Given this list of marker genes Prdx3, Ppdpf, Trappc4 (NCBI Gene Id 80545), Hnrnpr, Eif1ax, Sft2d1, Hs3st1, C4b, Oard1, Tex261, Sdf4, Aldoc, Acyp2, Gabarapl2, Rexo1, Rps14, Rplp1, Ddc, Qdpr, Adprh, Eif5, Cfdp1, Mrpl4, Arl6ip4, Hmox2, Rab3a, Epdr1, Prkrip1, Nedd8, Paqr6, Nudt9, Fdps, Fkbp3, Rnf5, Akap9, Ube2v1, Mif4gd, Copz1, Glrx3, Mpv17l2, Arl4d, Fkbp8, Polr1d, Nme2, Arl8a, Ak2, Gstm1, Ndufab1 (NADH:ubiquinone oxidoreductase subunit AB1), Ik, Dbi, Rpp30, Tm2d3 (NCBI Gene Id 77179, TM2 domain containing 3), Rbm8a, Cdkn2d, Mbp, Pdap1, Tmem11, Frg1, Rpl19, Plin3, Poc1a, Gpt, Erh, Babam1, Denr, Ptpn11, Hpf1, Marf1, Brd3, Dnajb2, Fam89b, Psme2, Creg1, Pgp, Ndufs2, Trp53bp2, Unc50, Gid4, Atp6v1d, Polr2i, Aptx, Ift27, Polr2a, Pithd1, Banf1, Psma5, Ptms, Ddah2, Pole4, Ddrgk1, Otud7b, Cenpx, Dlgap4, Ube2d1, Stmn1, Ip6k2, Wbp2, Cyc1, D8Ertd738e, Emc7, Ninj2, Nfix, Aup1, Sdhd, Snw1, Scg5, Serpinf1, Frat1, Pmm1, Ube2m, Arpc5l, Cox4i1, Zfp414, Gtf2b, Tnni1, Mrpl14, Mrps25, Tmt1a, Emc6, Mea1, Cd63, Eif3f, Rpl11, Mpdu1, Vps72, Sra1 (NCBI Gene Id 24068), Rps8 (ribosomal protein S8), Bckdha, Iftap, H2bc27, Shisa5, Cox8a, Map1lc3b, Emc8, Selenbp1, Polr2e, Atp5mc3, Scp2, Cops6, Vps28, Micos13, Ruvbl1, Naca, Rex1bd, Ypel3, Vgll4, Ndufs3, Psmb1, Ifi27, Phb2, Trappc6b, Ncoa3, Nudc (nudC nuclear distribution protein), Arl2, Prdx5, Rpl4, Otub1, Sec11c, Sh3bgrl3, Atp5pd, Calm3, Psmb6, Raly, Mrpl28, Psmb3, Ccdc85b, S100a1, Acot13, Aig1, Ech1, Cfl1, Mmp24os1, Tmem9, Txn2, Commd6, Pfdn1, Chmp5, Atp5mc2, Mvb12a, Litaf, Pde6d, Myg1, Rps19, Gabarap, Arf1, Enho, Rsu1, Snca, Aprt, Scand1, Ebpl, Vdac3, Znhit1, Ubxn1, Tbcb, Sfr1, Ccs, Brms1, Srsf9, Gatd3a, Dusp15, Fuca1, Apoe, Sf3b5, Hmgcl, Pdrg1, Spcs2, Ndufb11, 0610010K14Rik, Sbds, Psma2, Gstk1, H2-D1, Hspa1a, Sphk1, Npdc1 (neural proliferation, differentiation and control 1), Twf2, Imp3, Ubald1, Mrpl42, Ndufb5, Mrto4, Ppp4c, Manbal, Rab14, Tmem205, U2af1, Sparc, Vcf1, Tmem98, Eri3, 1110004F10Rik, Abca8a, Stard3nl, Zmat2, Commd5, Snrnp48, Grpel1, Cope, Gnao1, Ppp1r11, Tmed3, Dbndd2, Mrps17, Rack1, Nmral1, Tspo, Mxd4, Ssr2, Prelid1, Reno1, Tmed4, Vdac2 (voltage-dependent anion channel 2), Xpa, Spr, Sdhb, Srsf5, Dcps, Tmem106c, Dnlz, Map2k2, Dstyk, Tmsb4x, Commd9, Eif3k, Fcf1 (FCF1 rRNA processing protein), Acy1, Apod, Bfsp2 (NCBI Gene Id 12076), Ube2e2, Anxa2, Nkiras1, Taf9, Tuba1b, Hsp90ab1, Tmem50a, Rnasek, Rnf167 (NCBI Gene Id 74807), Gstm7, Scamp3, Ddt, Srd5a3, Dda1, Commd3, Medag, Rpsa, Mocs2, Pcbp2, Jtb, Atp5f1d, Adh5, Ndufa13, Rps11, Mrpl20, Ciao2b, Lamtor2, Cystm1, Pgls, Fbxo7, Klf7, Ctnnbip1, Rhoc, Ten1, Rabac1, Spag7, Impact, Eif1, Kdelr1, Pin1, Hsd17b10 (NCBI Gene Id 15108), Higd2a, Id3, Tmem147, Dtd1, Pdcd6, Dapk3, Sdf2l1, Ube2k, Tma7, Ccdc124, Tbcel, Commd10 (NCBI Gene Id 69456), Ociad1, Fth1, Selenok, BC031181 (cDNA sequence BC031181), Gadd45gip1, Lcmt1, Brd4, Lamtor5, Prdx1, Sdhc, B3gat3, S100b, Fus, Psmd4, Sf3b4, Fis1, Ubxn4, Rps20, Zmat5, Exosc7, Drap1 (NCBI Gene Id 66556), Bpgm, Smim14, Rab11b, Ptpmt1, Aldoa, Psmc5, Lrp4, Supt4a, Pdcd5, Jagn1, Tmed9, Hspe1, Akt1s1, Tmem14c, Czib, Cd9, Fbln1, Sin3b, Rplp0, Rpl28, Psmb5, 2310011J03Rik, Commd8, Klf13, Tmem109, Clpp, Ddx39b, Ino80e, Ctsz, Pdlim2, Eif1b, Ttc1, Mrps12, Gm2a (NCBI Gene Id 552880), Nabp2, Coa3, Polr2g, Dnajc3, Wdr83os, Ino80b, Anxa5, Zftraf1 (zinc finger TRAF type containing 1), Bag6, Tomm40, Hagh, Srm, Mycbp2, Mettl26, Abcg1, Esd (NCBI Gene Id 51790), Zfp317, Sar1b, Hras, Lsm10, Bnip3l, Iscu, Fn3k, Gstm5, Pagr1a, Ier2, Lefty1, Metrn, Ddost, Skap2, Dohh, Atp5f1c (ATP synthase F1 subunit gamma), Txndc12, Nosip, Ppia, Tcf7l2, Med28, Samm50, Pigp, Ppp1ca, Nudt16l1, Eif3m, Jund, Mtarc2 (NCBI Gene Id 67247), Elavl3, Vti1b, Tspan7, Srp9, Zcchc17, Gng11, Dnajc4, Cend1, Cavin3, Taf13, Mrpl48, Psmc4, Med8, Pex16, Imp4, Wipi1, Rab4b, Tppp3, Ebna1bp2, Mblac2, Snx15, Rpain, Lsm2, Cisd1, Mad2l2, Slc50a1, Mrpl30, Mpst, Rbm42, B2m, Timm22, Adrm1, Slc25a3, Gnb1, Cnih4, Rbfa, Atp5pf, Timm13, Car2, Rpl14, Mrpl15, Cttnbp2nl, Ap2a1, H2az1, Pqbp1, Med27, Ftl1, Ndufs4, Chd4, Tpt1, Pkm, Gemin7, Itgb5, Phlda3, Dctn3, Nfkbia (NCBI Gene Id 18035), Med19, Hnrnph3, Nme1, Tpgs1, Psmc3, Lmna, Mrps26, Arhgdia, Kif1a, Cycs, Eif4a3, Nol7, Mrps6, Zfp580, Smim30, S100a16, Gapdh, Mrpl18, Pou3f1, Gng10, Tpd52l2 (NCBI Gene Id 99179), Galk1, Elof1, Psma4, Rcor3, Tmod2, Uqcrc1 (NCBI Gene Id 66186), Sptssa, Hypk, Ndufv2, Zfp36, Arpc1a, Shisa4, Rpl18a, H2-K1, Glrx2 (glutaredoxin 2), Szrd1, Snrpd2, Pold2, Mrpl2, Taldo1 (transaldolase 1), Cacybp, Cetn3, H2bc4, Rbm25, Serbp1 (NCBI Gene Id 66870), Emc10, Cirbp, Micu3, Smim12, Ctsb, Cops5, Hmgn2, Syf2, Stmn4, Nt5c3b, Mtcl3, Eif3i, Ywhae, Psma3, Brcc3, Anapc16, Tmbim4, Rpl35, Myl6, Cdc37, Psip1, Dcdc2a, Junb, Mrpl41, Thap7, Trir, Lrrc4b, Stoml2, Arl6ip5, Rpl9 (NCBI Gene Id 20005), Nkx2-2, Tssc4, Tmem208, Gpatch11, Tm2d2, Erp29, Stmp1, Ndufa12, Idh3g, Rps5, Abcf1, Psmd13, Ndufs6, Parl, Tomm22, Srp14, Ngdn, Pnrc1, Hint1, Pigyl, Dmac1, Sys1, Mettl5, Anp32b, Cuta, Il11ra1, Mapre3, Cyb5r3, Paxx, Med4, Ptpn1 (NCBI Gene Id 19246), Atp6v0b, Ubb-ps, Pcbp4 (NCBI Gene Id 80436), Bax, Ciao2a, Zscan26, Ap2s1, Snrpb, Opalin, Oaz1, Clta (NCBI Gene Id 230110), Hcfc1r1, Hdgf (heparin binding growth factor), Fos, Smad7, Ptp4a2, Wdr18, Nr4a1, Auh, Atp5mc1, Tsn, Arpc1b, Hmgb1, Dnajc9 (NCBI Gene Id 68076), Ift22, Mmp2, Ctsl, Abhd17a, Eef1g, Dynlrb1, Nsmce1, Samd4, Grina, Swi5, Sertad1, Nucks1, Ssna1 (SS nuclear autoantigen 1), Atraid, Sarnp, Hmgn1, Eci1, Ldhb, Zfyve21, Pllp, Ube2e3, Ubl7, Rpl24, Snrnp70, Mdh2, Ndufb10, Atp5po, Snrpd3, Arpc4 (NCBI Gene Id 68089), Camk2n1, Serpinb1a (NCBI Gene Id 66222), Tmem59l, Rpl7a, Rsrp1, Gtf2h5, Psmd6, Cdk2ap2, Mospd3, Mrpl24, Vps29, Cnbp (cellular nucleic acid binding protein), Psmd8, F8a, Psmb4, Psma6, Rps13, Uqcrh, Trappc5, Camk1, Tmed10 (NCBI Gene Id 68581), Ndufa10, Sdc4, Tjp1, Prpf38b, Rps4x, Eef1e1, Faf2, Slc25a4, C1d, Fam162a, Ncl, Dhrs4, Sec11a, Emc4, Dusp3, Rps2, Fkbp2, U2af1l4, Slc35a2, Tmem126a (NCBI Gene Id 66271), Tubb5, Snrnp27, Rtf1, Surf1, Cltb, Atp6v0e, Nsd3, BC004004, Ntan1, Rheb, Tmem14a, Rnf181, Haghl, Nat9, Spcs1, Atp5mg, Lamtor1, Eif5a, Kxd1, Stx8, Tuba1a, Aurkaip1, Cfap20, Btg2, Pmp22, Naxe, Rpl18, Chst12, Selenos, Tsen34, Bcas2, Pop5, Map1lc3a, Gipc1, Card19, Ybx1, Polr2c (polymerase (RNA) II (DNA directed) polypeptide C), Trappc3, Slu7, Akr7a5, Gpm6b, Pdzd11, Aopep, Cyb5a, Reep5, Hdhd2, Pycr2, Ubb, Set, Aamp, Skic8, Dpm1, 1700063D05Rik, Tm2d1, Phf5a, Gltp, Immp1l, Prr13, Lamtor4, Tmed1, Antkmt, Gstm6, Tecr, 2210016L21Rik, Rpl13, Dynll2, Rpl10, Rpl7, Tomm6, Zfp771, Prnp, Psmb7, Atf4, Tusc2, Cryzl1, Pfn1, S100a13, Yif1a, Rps10, Emd, Hsd17b8, Sec13, Hsbp1, Pcna, Rchy1, Rbm3, H3f3a, Tbcc, Etfb, Tfam, Slc25a27, Plekhj1, Eif6, Ssr4, Itgb1bp1, Snrpc (NCBI Gene Id 20630), Twf1, Idh2, Pfdn6, Cox6a1, Myl12a, Rnase4, Mrpl12, Yju2, Pfdn5, Rps24, Dusp23, Nudt3, Trnau1ap, Btf3, Vamp2, Rpl13a, Cfap298, Ormdl2, Wasf2, Ppp1r35, Paip2, C1qbp, Commd1, Mrps18b, Dhrs7, Cst3 (cystatin C), Gstp1, Cryab, Arl3 (NCBI Gene Id 56350), Mien1 (NCBI Gene Id 66428), Rps18, Aga, Snrpa1, Dgcr6, Eif3g, Rtl8c, Tsc22d4, Phpt1, Ube2e1, Atg3, Cdc123, Glrx5, Ccdc12, Fau, Txnl4a, Tmem242, Bcap31, Npm1, Srcin1, Paip1, Faim2, H2ax, Ethe1, Aarsd1, Srpk2, Mfge8, Tpm3, Nsfl1c, Zfpl1, Hsp90aa1, Jun, Mrps10, Hexb, Cald1, Olfml1, Manf, Tmem59, Bloc1s1, Calm1, Nfic, Plaat3, Emg1, Lmo4, Atp6v1f, Fah, Rsrc2, Rassf1, Txndc9, Ndufa8, Mapt, Akr1a1, Prrg2, Laptm4a, Ndufs7, Tamalin, Gjb1, Sumo1, Mydgf, Islr, Vkorc1, Grhpr, Rtn2, Rps3, Scd3, Tubb4b, Mrps15, Il18, Faim, Gabarapl1, Psma7, Psmd7, Pla2g12a, Mif, Nubp2, Dnajc24, Ndufc2, Pfdn2, Slc6a8, Rnf126, Ptma, Mpc1, Uba52, Psenen, Tmub1, Syngr2, Mpc2, Ube2b, Tmem219, Rpl29, Bmyc, Ndrg2, Arf5, Brk1, Ostc, Qpct, Ap1s1, Bri3, Anapc11, Chaserr, Coq7, Mrps24, Rtraf, Josd2, Gtf3a, Calr, Selenow, Psmb2, Oaz2, Smdt1, Fbxo2, Rrp36, Gtf2a2, Grcc10, Trmt112, Ddhd2, Rps9, Tmem160 (transmembrane protein 160), Ppig, Guk1, Rbm26, Xbp1, Gnptg, Nop16, Calm2, Tmem223, Snrpd1, Pcolce2, Arpc3, Ap4s1, Dnajc19, Rpl8, Thap3, Ahsa1, Ndufb7, Dpysl2, Elovl1, Bsg, Ndufa9, Ncbp2as2, Cnpy3, Chd7, Sox10, Ndufs8, H3f3b, Sf3b2, Snx3, Herpud1, Mdh1 (NCBI Gene Id 83566), Ift43, Sod2, Pacsin1, Cuedc2, Cfap36, Arhgap23, Rpl3, Hapln2, Xaf1, Psma1, Dnajc15, Eef1d, Atp6v1g1, Tmem234, Rexo2, Tpm1, Chmp2a, Mrpl27, Wrap73, Mlf2, Pebp1, 4933434E20Rik, Eif2b2, Aldh2 (aldehyde dehydrogenase 2, mitochondrial), Etv1, Acp1, Dnajb1, Ndufb8, Cerox1, Rogdi, Rpl6, Nop53, Aip, Ppib, Nfkbib, Cnpy2, Timm17b (NCBI Gene Id 21855), Pdgfa (NCBI Gene Id 18590), Mrpl58, Dusp26, Nelfe, Atp6v0c, Pomp, Ndufb6, Capzb, Rbm39, Rrp1, Smarcb1, Pih1d1, Yipf3, Gcat, Npc2, Chchd2, Pip4p1, Smim29, Pttg1, Ergic3, BC005624, 2310033P09Rik, Atg101, Pcsk1n, Eif3h, Tax1bp1, Edf1, Nop56, Acot7, Scnm1, Use1, Jkamp, Gtf2f1, Slc25a5, Dad1, Rps3a1, Stub1, H2az2, Plgrkt, Snrpa, Rhog, Znrd2, Kctd13, Wbp1, Rnf7, Sgf29, Psmc2, Sirt2, Naa10, Csnk2b, 1190005I06Rik, Phb1, Upf3a, Ndufb9, Map2k7, Zcrb1, Sfxn5, Stx4a, Dynll1, Suclg1, Urod, Styx, Ddit3, Mageh1, Ranbp1 (RAN binding protein 1), Dnajc8, Aif1l, Ppp1r14a, Exosc5, Praf2, Lsm4, Pacsin3, Skil, Crip2 (cysteine rich protein 2), Selenom, Zfp524, Sumo3, Vamp8, Rnaseh2c, Macrod1, Rpp25l, Timm17a, Puf60, Sod1, Bcl7c, Rab5c, Tfpt, Mid1ip1, Mrps18a, Pabpn1, Cep20, Park7, Hax1, Rpl21, Atp5pb, Rpl17, Aimp2, Smim1 (NCBI Gene Id 72548), Rab10os, Nr2c2ap, Cox5a, Tle5, Ahsa2, Uchl5, Psph, Rps7, Tpr, Eef1b2, Cmtm5, Psmd11, Gtf2f2, Gpx4, here is a description of the gene set: species: Mus musculus from publication Tabula Muris Consortium (PMID 32669714) Mouse Gene Set: TABULA_MURIS_SENIS_BRAIN_NON_MYELOID_OLIGODENDROCYTE_AGEING